Given this list of marker genes AGO2, EIF4ENIF1, TNRC6A, TNRC6B, PABPC1, TENT4A, CNOT7, TNRC6C, ZFP36, CPEB3, CNOT1, TENT4B, TOB1, BTG2, POLR2G, here is a description of the gene set: Human Gene Set: GOBP_REGULATION_OF_NUCLEAR_TRANSCRIBED_MRNA_POLY_A_TAIL_SHORTENING species: Homo sapiens Any process that modulates the frequency, rate or extent of poly(A) tail shortening of a nuclear-transcribed mRNA. Poly(A) tail shortening is the decrease in length of the poly(A) tail of an mRNA from full length to an oligo(A) length.